Given this list of marker genes Nol10, Noc4l, Dnttip2, Heatr1, Rcl1, Fbll1, Rps9, Dimt1, Rps27a, Nol7, Utp14a, Utp4, Rps23, Rps7, Tbl3, Wdr3, Utp15, Utp6, Utp25, Rps11, Rps5, Wdr36, 2810004N23Rik, Bms1, Rrp7a, Rps17, Rps27rt, Utp3, Rps13, Rps12, Imp4, Rps28, Fcf1, Utp11, Rrp9, Rps19bp1, Rps27, Fbl, Pdcd11, Xrcc5, Rps8, Rps6-ps4, Mphosph10, Rps4x, Utp20, Dcaf13, Nop56, Rps14, Pwp2, Rps16, Wdr46, Utp23, Nop14, Emg1, Krr1, Ngdn, Pno1 (partner of NOB1 homolog), Rps6, Utp18, Utp14b, Wdr43, Snu13, Rps19, Dhx37, Nop58, Rps15a, Prkdc, Aatf, Exosc10, Wdr75 (NCBI Gene Id 96871), Rps3a1, Nat10, Rps24, Nol6, Imp3, here is a description of the gene set: species: Mus musculus Mouse Gene Set: GOCC_SMALL_SUBUNIT_PROCESSOME A large ribonucleoprotein complex that is an early preribosomal complex. In S. cerevisiae, it has a size of 80S and consists of the 35S pre-rRNA, early-associating ribosomal proteins most of which are part of the small ribosomal subunit, the U3 snoRNA and associated proteins.